Given this list of marker genes Il1b, Slc38a1, Slc17a8, Fxyd1, Slc6a1, Avp, Mapk9, Rab3gap1, Itgb1, Pla2g4a, Psen1, Avpr1b, Pla2r1, Htr6 (5-hydroxytryptamine (serotonin) receptor 6), Gabbr1, Adora2a, Oxt, Htr2c, Mif, Ptges, Fabp3, Tnfsf11, Abat, Kmo, Map2k6, Pla2g10, Slc7a5 (NCBI Gene Id 270102), Nr3c1, Grin2b, Slc36a2, Ace2 (angiotensin converting enzyme 2), Arhgef11, Edn1, Ntsr1, Abcb11, Grik1, Erfe, Syt4, Slc38a3, Avpr1a, Tnfrsf11a, Stxbp1 (syntaxin binding protein 1), Cltrn, Pla2g3, Slc12a2, Il1a, Acsl1, Acsl5, Sstr4, Dpysl2, Cyp4a31, Arl6ip1, P2rx7 (purinergic receptor P2X, ligand-gated ion channel, 7), Cck, P2ry2, Hrh3, Dtnbp1, Acsl6 (NCBI Gene Id 216739), Trh, Cyp4a10, Cyp4a32, Pla2g6, Agt, here is a description of the gene set: Mouse Gene Set: GOBP_POSITIVE_REGULATION_OF_ORGANIC_ACID_TRANSPORT studied in species Mus musculus Any process that activates or increases the frequency, rate or extent of the directed movement of organic acids into, out of or within a cell, or between cells, by means of some agent such as a transporter or pore.